The following is a description of a gene set: Any process that increases blood-brain barrier permeability, the quality of the blood-brain barrier that allows for a controlled passage of substances (e.g. macromolecules, small molecules, ions) into and out of the brain. species: Homo sapiens Human Gene Set: GOBP_POSITIVE_REGULATION_OF_BLOOD_BRAIN_BARRIER_PERMEABILITY, and this is the list of marker genes: TJP2, ANGPT1, TJP1, OCLN, TJP3